The following is a description of a gene set: part of: Diseases of signal transduction by growth factor receptors and second messengers species: Homo sapiens FLT3 is a type III receptor tyrosine kinase (RTK). The extracellular domain consists of 5 immunoglobulin (Ig) domains that contribute to dimerization and ligand binding. The intracellular region has a juxtamembrane domain that plays a role in autoinhibiting the receptor in the absence of ligand, and a bi-lobed kinase region with an activation loop and the catalytic cleft. Signaling through FLT3 occurs after ligand-induced dimerization and transautophosphorylation, and promotes signaling through the MAP kinase, PI3K and STAT5 pathways, among others. FLT3 signaling promotes cellular proliferation and differentiation and contributes to haematopoeisis. FLT3 is mutated in up to 30% of acute myeloid leukemias. ~25% of the FLT3 mutations in AML cases occur as internal tandem duplications (ITDs) either in the juxtamembrane domain region encoded by exon 14 or the tyrosine kinase domain (TKD), while ~7-10% of AML cases contain FLT3 missense mutations in the TKD. These mutations all support ligand-independent activation of the receptor and result in constitutive activation and signaling. In rare cases, the FLT3 locus is also subject to translocations that generate constitutively active fusion proteins. Oncogenic FLT3 activity can be targeted with tyrosine kinase inhibitors, although resistance often arises due to secondary mutations or activation of bypass pathways. Reactome Pathway: FLT3 signaling in disease, and this is the list of marker genes: PIM1, NRAS, BCL2L1, GAB2, GRB2, KRAS, CBL, ETV6, PIK3R1, UBC, PTPN11, SPTBN1, PIK3CA, ZMYM2, MYO18A, FLT3LG, STAT5B, UBA52, FLT3, UBB, TRIP11, RPS27A, NOX4, GOLGB1, HRAS, CDKN1A (NCBI Gene Id 1026), SOS1, STAT5A